Given this list of marker genes Trp53, Cables1, Pten, Errfi1, Stk11, here is a description of the gene set: Mouse genes annotated to increased endometrial carcinoma incidence (MP:0004868) retrieved from the Mouse Genome Informatics database via MouseMine from publication Motenko H, Neuhauser SB, O'Keefe M, Richardson JE (PMID 26092688) species: Mus musculus Mouse Gene Set: MP_INCREASED_ENDOMETRIAL_CARCINOMA_INCIDENCE